The following is a description of a gene set: species: Homo sapiens Reactions triggered in response to the presence of a Gram-positive bacterium that act to protect the cell or organism. Human Gene Set: GOBP_DEFENSE_RESPONSE_TO_GRAM_POSITIVE_BACTERIUM, and this is the list of marker genes: DEFB107A, RNASE7, FGR, DROSHA, GBP7, DEFB136, DEFB106B, GPR15LG, B2M, ZG16, NPY, PLA2G2A (NCBI Gene Id 5320), CTSG, TLR2, CD36, ACP5, H2BC6, LYG2, DEFB107B, RNASE6, GBP2, FCN2, LTF, DEFB114, TBK1, H2BC10, HCK, DEFB118, DEFB119, PGLYRP4, IL12A, MMP7, HAVCR2, LCE3B, P2RX7 (purinergic receptor P2X 7), HAMP, LYG1, RNASE2, APP, TAC1, IL7R, KLRC4-KLRK1, H2BC7, SSC5D, NOD1 (nucleotide binding oligomerization domain containing 1), SEH1L, H2BC21, IL1B, DEFB128, TIRAP, DEFA5, CHGA, DEFB103A (defensin beta 103A), IL27RA, RNASE13, LALBA, FAU, H2BC12L, IL6R, DEFA1, HLA-A, LCE3C, HLA-E, MYD88, DEFA1B, ADAM17, LTA, GBP4, DCD, PGLYRP3, IL17F, STAB2, IL18 (interleukin 18), KLRK1, NLRP6, PPP1R11, CASP4, RNASE8, DEFB104A, DEFB1, H2BC8, DEFB106A, IL17A, HMGB2, CARD9, GSDMD, GBP6, RNASE11, TNFSF8, DEFB103B, DEFA3, MR1, TRAV27, H2BC11, CRP, PYCARD, PLA2G1B, RNASE12, IL6, MPEG1, RPL39, DEFA4, DEFB104B, EPHA2, ANG, RARRES2, H2BC4, RNASE9, LCE3A, H2BC12, ROMO1, PGLYRP2, C5AR1 (complement C5a receptor 1), CALCA, ADM, RIPK2 (NCBI Gene Id 8767), REG3G, TNF, RNASE10, DEFA6, SPRR2A, DMBT1, RNASE4, MBL2, LBP, LYZ, CAMP, RNASE3, NCF1, PGLYRP1, VIP, KRT6A, RNASE1, DEFB4A, TNFRSF14